The following is a description of a gene set: Genes up-regulated in natural T reg versus T conv. Human Gene Set: GSE14415_NATURAL_TREG_VS_TCONV_UP from publication Haribhai D, Lin W, Edwards B, Ziegelbauer J, Salzman NH, Carlson MR, Li SH, Simpson PM, Chatila TA, Williams CB (PMID 19265124) The gene expression profile of peripheral Foxp3+ natural regulatory T cells isolated from Foxp3/EGFP bicistronic mice was compared to that of in vitro-induced regulatory T cells and to CD4+ conventional (Foxp3-) T cells. The role of the regulatory T cell transcription factor Foxp3 in shaping the transcriptosomes of natural and induced regulatory T cells was analyzed using mice expressing a mutant FOXP3-EGFP fusion protein (Foxp3deltaEGFP). We used gene expression microarrays to examine the transcriptional programs of natural and induced regulatory T cells and the function of Foxp3 in organizing the transcriptosomes of the respective cell type studied in species Homo sapiens, and this is the list of marker genes: ZBTB34, MS4A3, VAMP2, SLC25A51, ZC3H6, CFAP68, NEB, CD226, RABGAP1L, FOXP1, DEFB4A, SMAP2, CXCR6, TRIM24, TBCEL, ATMIN, YPEL5, ZBTB38, DAZAP2, ZBED3, CD96, OCIAD2, ITIH5, RUNX2, SRGAP3, ORAI1, ASB7, CPT1A, LGALS3BP, HLA-B, IRF9, IFIT3, MAML1, FOXN3, TMEM71, CD47, ARHGAP35, CCNK, ZNF496, EID2B, PGAM2, CTSE, CRMP1, SPATA6, GIT1, NFKBIA, NUCB1, SPRED2, CBLB, TIGIT, ZNHIT6 (NCBI Gene Id 54680), ARHGAP15, DVL3, ATXN1, CHIT1, PEAR1, MRPS18C, CIRBP, MBD2, B3GNT5, USP3, CCDC125, MX1, CTLA4, MANEA, SMAD7, SAMSN1, CTSO, SETBP1, ZMIZ2, ZNF486, PPFIBP1, CSF2, CD164, GNPDA2, TMEM106B, TMEM203, ZRANB1, BCL2L1, RASGRP1, ZNF333, TACC2, GIMAP5, IL18R1, FBXO32, TLCD3A, CCNI (NCBI Gene Id 10983), ANKRD55, ARHGAP26, MYLIP, BTBD19, PPP3CC, NHLRC3, PPM1H (protein phosphatase, Mg2+/Mn2+ dependent 1H), MAPK8IP3, MAP4K3, CROT, CD3E, HNRNPDL, F2RL2, ANKRD33B, CAST, MOSMO, JARID2, RBAK, GAB3, PCNX1, RAB12, ICA1 (islet cell autoantigen 1), EPSTI1, TTC39B, MFHAS1, GPR171, FBXL20, ZBTB25, TXNIP, BCL2L11 (BCL2 like 11), NOP53, TOX, SLC38A9, SAA3P, GPR55, CIZ1, FILIP1, ARL5B, F2RL1, MAF, PTPN13, CHMP1B, APC, GRAMD1B, TSC22D3, GSKIP, UBASH3B, ARHGEF12, CNTNAP3, EMB, PTGER2, IFNGR1, RBM3, PDCD4, IRAK3, TRIM34, IL10RA, SFXN3, PDE4D, ADCK2, PDCD1, CORO2A, CRTC3, H1-0, IL1RL1, PSEN2, ITGA1, ADAMTS6, FBXL17, NOSIP, PER1